The following is a description of a gene set: EPHB-mediated forward signaling Mouse Gene Set: REACTOME_EPHB_MEDIATED_FORWARD_SIGNALING species: Mus musculus, and this is the list of marker genes: Actr3, Src, Hras, Arpc2, Ephb3, Rhoa, Rac1, Grin1 (glutamate receptor, ionotropic, NMDA1 (zeta 1)), Lyn, Cdc42, Actg1, Pak1, Arpc5, Efnb3, Fyn, Efnb2, Ephb2 (Eph receptor B2), Actb, Rasa1, Rock1, Ptk2, Ephb6, Ephb4, Itsn1, Ephb1, Arpc1a, Yes1, Efnb1 (NCBI Gene Id 13641), Arpc4, Kalrn, Sdc2, Arpc3, Actr2, Arpc1b, Rock2, Arhgef28